Given this list of marker genes Mapk8, here is a description of the gene set: part of: Activation of BH3-only proteins studied in species Mus musculus electronically inferred by orthology from the curated human pathway This event has been computationally inferred from an event that has been demonstrated in another species.<p>The inference is based on the homology mapping from PANTHER. Briefly, reactions for which all involved PhysicalEntities (in input, output and catalyst) have a mapped orthologue/paralogue (for complexes at least 75% of components must have a mapping) are inferred to the other species. Reactome Pathway: Activation of BMF and translocation to mitochondria